The following is a description of a gene set: studied in species Mus musculus Mouse Gene Set: GOBP_GANGLIOSIDE_CATABOLIC_PROCESS The chemical reactions and pathways resulting in the breakdown of ganglioside, a ceramide oligosaccharide carrying, in addition to other sugar residues, one or more sialic residues., and this is the list of marker genes: Hexb, Neu4 (sialidase 4), Neu3, Hexa, Neu2, Glb1, Neu1, Gm2a